Given this list of marker genes MYDGF, CCDC32, ZNRF2P1, USP42, STARD8, IL36RN, PNP, C15orf39, POC1B, LINC01013, RNFT2, CARD6, TKFC, TSPEAR-AS1, KARS1, TXNDC11, PHLDA2, TINF2, CALHM4, CCN4, FGF14, TMEM255B, CLDN4, C19orf12, ENSG00000284837, NEUROD2, RC3H2, NGFR, RCHY1, RFPL3, HASPIN, HELZ2, ICOS, ARHGEF17, VSIG2, EREG, TUBA4B, RAB3IL1, FAM83G, EQTN, EXOC3L4, GIMAP8, SLC22A15, PPIF, PLEKHO1, ANK3, BTN2A3P, LGMN, CBLC, PELO, PPCDC, SLC2A3, PCDHGB5, HLA-DOB (major histocompatibility complex, class II, DO beta), FOXN3-AS2, ENTPD5, SYNPO, KRTAP4-3, LIMS2, TRIM21, IHH, LINC00623, SIPA1L1, FAT1, AP4S1, KCNMB1, IGFL1, NEBL, ITK, SOAT2, KRTAP4-7, CARD16, SLC12A7, TPMT, CAVIN3, MARCO, TLNRD1, DYNC1H1, SGCZ (sarcoglycan zeta), FAM219A, TJP1, PCLAF, MYO1E, PLAAT4, MOBP, MYL12A, SCPEP1, EMP1, TLR6, PEA15, SH3BP5, RBCK1, LINC01521, CEP170B, ANKRD36C, OR3A2, CEP57L1, STAT1, MS4A15, CLCN7, LPAR5 (lysophosphatidic acid receptor 5), CREB5, ID3, MGAM, TNF, TP53AIP1, BTN1A1, BANP, HCAR3, VN1R3, ST20, TMED9, ARHGEF5, PTP4A3, GRIN3A, ZNF385C, HMGA2, HPSE2, SHC3, SLAMF8, UBXN4, GBP1, SCARF1, KLK13, CD3G, HHAT, C6orf132, UPB1, IL12RB1, RALA, NLRC5, FAM230C, OR5H1, GIMAP6, SIL1, FANCA, UGT2B4, PTCHD4, CTTNBP2, SDSL, D2HGDH, DDX60L, CD74, DIAPH1, PDLIM4, VWA8-AS1, SND1, SLC16A11, RUNX3 (NCBI Gene Id 864), ZNF208, BTN3A1, IGHG1, DLGAP2-AS1, SVOP, TCF7L2, RGS22, UGT2B28, PTTG1, MYH3, CRYM, LYZL4, CCND2, LAT2, SUB1, RAB27A, FAP, DHRS12, SSTR5, SERPINB8, KRT77 (NCBI Gene Id 387860), DTL, SECTM1, MTHFD2L, ZNF804B, HM13, RTP4, LILRA2, APOL2, ADCY4, BAK1, JAM2, KCNJ8, PDZK1, PAX8, OGFOD3, DESI1, RNF215, KIF13A, FOXP2, AMN1, ADCY2, HIVEP3, MDGA1, LLCFC1, here is a description of the gene set: Genes up-regulated in monocyte-derived macrophages primed by IFNG: untreated versus interferon alpha. studied in species Homo sapiens Type I IFN-inducible gene expression in human blood monocytes primed with Type II IFN. from publication Tassiulas I, Hu X, Ho H, Kashyap Y, Paik P, Hu Y, Lowell CA, Ivashkiv LB (PMID 15467722) Human Gene Set: GSE1740_UNSTIM_VS_IFNA_STIMULATED_MCSF_IFNG_DERIVED_MACROPHAGE_UP